Given this list of marker genes TMEM175, CLN3, SLC26A6, SLC26A3, OCA2 (NCBI Gene Id 4948), SLC45A2, CFTR, here is a description of the gene set: Any process that increases the internal pH of a cell, measured by the concentration of the hydrogen ion. studied in species Homo sapiens Human Gene Set: GOBP_INTRACELLULAR_PH_ELEVATION